The following is a description of a gene set: Any process that modulates the frequency, rate or extent of T cell activation via T cell receptor contact with antigen bound to MHC molecule on antigen presenting cell. studied in species Homo sapiens Human Gene Set: GOBP_REGULATION_OF_T_CELL_ACTIVATION_VIA_T_CELL_RECEPTOR_CONTACT_WITH_ANTIGEN_BOUND_TO_MHC_MOLECULE_ON_ANTIGEN_PRESENTING_CELL, and this is the list of marker genes: HAVCR2, HLA-DMB, LGALS9, LGALS3, CD81, LILRB1